The following is a description of a gene set: part of: Metabolism of RNA Co-transcriptional pre-mRNA splicing is not obligatory. Pre-mRNA splicing begins co-transcriptionally and often continues post-transcriptionally. Human genes contain an average of nine introns per gene, which cannot serve as splicing substrates until both 5' and 3' ends of each intron are synthesized. Thus the time that it takes for pol II to synthesize each intron defines a minimal time and distance along the gene in which splicing factors can be recruited. The time that it takes for pol II to reach the end of the gene defines the maximal time in which splicing could occur co-transcriptionally. Thus, the kinetics of transcription can affect the kinetics of splicing.<br> There are two classes of intronless pre-mRNAs (mRNAs expressed from genes that lack introns). The first class encodes the replication dependent histone mRNAs. These mRNAs have unique 3' ends that do not have a polyA tail. The replication dependent histone mRNAs in all metazoans, as well as Chlamydomonas and Volvox fall into this class. <p>The second class of mRNAs end in polyA tails, which are formed by a mechanism similar to that which poly-adenylate pre-mRNAs containing introns. In the intronless genes there is a different method of replacing the 3' splice site that activates polyadenylation. Reactome Pathway: Processing of Capped Intronless Pre-mRNA species: Homo sapiens, and this is the list of marker genes: SNRPB, SNRPE, PAPOLA, CSTF2T, PCF11, CPSF6, CSTF1, CPSF4, CPSF2 (NCBI Gene Id 53981), SNRPD3, CSTF3, LSM11, CPSF7, CSTF2, CPSF1, NUDT21, NCBP1, SYMPK, CPSF3, FIP1L1, PABPN1, NCBP2, SNRPF, WDR33, ZNF473, LSM10 (NCBI Gene Id 84967), SLBP, SNRPG, CLP1